Given this list of marker genes Tnfrsf4, Tnfrsf13c, Tcf3, Il4, Ada, Bst1, Peli1, Ephb2, Ighd, Il7, Chrnb2, Il2 (interleukin 2), Tirap, Bcl2, Nckap1l, Slc39a10, Tlr9, Vav3, Cd40lg, Mef2c, Il5, Tfrc, Bmi1, Ticam1, Cd81, Cdkn1a, Tnfsf13, Cd38, Sash3, Clcf1, Il3, Tnfsf13b, Irs2, Cd40, Il21, Wnt3a, Nfatc2, Gpr183, Btk, Cd74, Bcl6, Tlr4, Ptprc, Cd320, Prlr, Card11, Mif, Il13, Ighm (NCBI Gene Id 432703), Atad5, here is a description of the gene set: Any process that activates or increases the rate or extent of B cell proliferation. Mouse Gene Set: GOBP_POSITIVE_REGULATION_OF_B_CELL_PROLIFERATION studied in species Mus musculus